The following is a description of a gene set: Genes predicted to be targets of miRBase v22 microRNA hsa-miR-641 in miRDB v6.0 with MirTarget v4 prediction scores > 80 (high confidence targets). from publication Chen Y, Wang X (PMID 31504780) studied in species Homo sapiens Human Gene Set: MIR641, and this is the list of marker genes: BRINP3, RRS1, EFCAB14, LRATD2, MMD, PUS10, DUSP3, DDX3X, RNF145, SRSF12, SNX9, BDP1, LAYN, PCDH9, LRP6 (LDL receptor related protein 6), AFTPH, UBE2D3, KIF13B, USP33, ATP6V1C2, OMG, ZEB1, KLHL28, PRSS12, ZNF106, DNAJC27, KPNA2, KLF12, B3GALNT2, PRP4K, GNAQ, GRIP1, COL4A3, APOOL, PTPRG, DOK6, SERPINB9, RSPRY1, SECISBP2L, SETDB2, STEAP4, PRKACB, LPCAT2, EFNB1, KCNB1, PODXL, FEM1C, CNTN1, GORASP2, ZNF804A, MRTFB, CDK8, SDR42E1, MARCKSL1, RPIA, PALS1, KCNJ2, NRG2, MAL2 (NCBI Gene Id 114569), CGGBP1, NUS1, PTGR1 (prostaglandin reductase 1), MAPK8IP3, FAM220A, PARD3, FZD8, USP44, PAM, RFX7 (NCBI Gene Id 64864), PAK5, LRRC8B, IPO7, SEMA3A, PPP6C, DDX5, YWHAB, WAPL, MAGEE1 (NCBI Gene Id 57692), GBF1, CYSLTR1, RELN, IRS2, SOX6, SELENOP, ENPEP, ZBTB41, TCTN2, CSNK2A1, DEPDC1B, CSNK1G3, BNC1, NEO1, BCL2L11, GNG12, TGFBR3, TRIM10, DENND11, MINDY2, TRPS1, MYH10, MARCKS, LIN28B, EEIG2, ZC3H12C, ROBO1 (NCBI Gene Id 6091), PTGS2, MBNL3, RIMS1, FAT1, ADAT2, PCSK2, PCDHA2, COL24A1, AMOT, EIF4A2, DENND1B, SNX2, ZC3H18, TGFBR1, TP53INP2, CREBZF, TMEM263, LRRTM1, CPED1, GPALPP1, DOCK9, SATB1, RMI1, STAM, PLA2R1, ITGA9, ZHX1, EIF4G2, KIAA1143, AFF4, TNPO3, IFFO2, PAK2, RGL1, RAPGEF6, METTL21A, PROSER2, SLC4A7, SMIM13, KIAA1549, PMAIP1, SYTL4, EBF1, EIF5, CNOT9, PTPN4, TLNRD1, NBN, SBNO1, POLR3D, ACYP2, METTL8, SLC4A8, OTUD4, HP1BP3, NRIP1, TRUB1, MAN1A1, CDKL5, PTPDC1, KLHL8, COLEC12, ZFAND5, SEC14L1, GPC5, WBP4, ARHGAP32, IRX5, STRN3 (striatin 3), SYT6, TNFRSF21, RCOR1, ELOVL6, PDE3B, VEZF1, ZDHHC15, CAMTA1, RPS6KA4, UTRN, RAD21, NUFIP2, ITGB8, ZFHX3, MYOZ2, OSBPL8, SCGB2A2, ZNF519, B3GLCT, ELAVL4, MAX, GABRB2, PDE4D, NCBP1, ANKRD13C, ATP9A, CCDC6, BRAP, SCN2B, DTWD2, LHX6, STC1, CNTNAP2, HSF5, BTLA, LRRC8C, NUP62CL, DAAM1, SOS2, TMEM47, MAPK10, SNRK, ZRANB2, NR4A3, IL17RA, LRRC2, ROR2, SLC39A11, ERLIN2, RPS6KB1, CNOT6, ARID5B, GRK3, KLHL32, C10orf88, GPATCH2L, HOXB2, SIAH2, KDM5A, TTC14, USP37, DCUN1D5 (NCBI Gene Id 84259), MAL, PPP3CB, SLC10A7, LEKR1, NCOR1, LYSMD2, FAM47B, ZCCHC4, UBE2V2, PDCD4, MAPK8, ZNF677, RBMS3, SRP72, INO80D, DBT, SERPINI2, ATXN3, FNIP1, ZNF714, MAP1B, GEM, LXN (latexin)